Given this list of marker genes Lcmt2, Trmt12, Tyw5, Tyw3, Tyw1, here is a description of the gene set: The chemical reactions and pathways involving wybutosine, 3H-imidazopurine-7-butanoic acid, 4,9-dihydro- alpha-- 4,6-dimethyl-9-oxo- 3-beta-D-ribofuranosyl methyl ester, a modified nucleoside found in some tRNA molecules. studied in species Mus musculus Mouse Gene Set: GOBP_WYBUTOSINE_METABOLIC_PROCESS